Given this list of marker genes RNF4 (NCBI Gene Id 6047), TIMP2, STAMBPL1, TRIM15, PTPRA, FKBP9, RRAS2, NFIA, CYTH1, RAB33A, HIVEP1, KRCC1, ARL4A, SREBF1, WDR31, SERINC4, THRA, ATAD2B, IL10RA, PDZD11, ANKRA2, DOCK2, DLAT, PPP4R2, SAV1, VPS37B, LAMP2, SLC23A2, CSRP1, ASAP1, DEXI, MYCL, LINC00612, TYK2, ETNK1, COLEC12, CALHM2, STIP1, HSD17B6, TMEM243, CPEB1, SERTAD3, SLC7A8, GOT1, RNF14, CDC27, DOC2A, LRRK2, BTRC, CDV3, CLDND1, NEK1, SLC44A2, B4GALT6, STX3, UBXN10, PRAMEF2, CACNG2, HIVEP3, ABCC3, HEXB, PRDM9, VPREB3, SLC37A2, ETHE1, RAB38, SAP30, TBC1D23, GALNT11, DUSP2, MLC1, CSF1, RRS1, FOLR1, STK4, IGF1, SP110, SLC25A17 (NCBI Gene Id 10478), RUNX2, ATP6V1G2, TNFSF10, P2RY14, PTH1R, FAS, SUPV3L1, UBR4, SIK1, EMC2, HMGN3, IFT57, WIPI1, NDUFA5, CACNG3, ABHD5, RNF135, PRKD3, CXCL3, EDEM1, PFKM (NCBI Gene Id 5215), NAP1L5, ASCL1, SLC25A28, SECTM1, VRK2, RAB10, GLA, ZBTB8A, CNP, NPAS1, NCOA5, G3BP2, CCNL1, LPAR4, CDH5, UBE2V1, TMEM39A, B3GNT2, PTPRT, CTSZ, BHLHE41, GYPC, SYNGR1, SLC17A3, QKI, SEPTIN11, KCNS1, EIF2D, ABCD3, MELK, PFKP, NT5C3A, OGFR, PHTF2, WARS1, AVL9, IL5, RGS2, SPRYD7, MRPS28, FAF1, SPRED2, SLC34A2 (NCBI Gene Id 153010), CIP2A, PCDH7 (NCBI Gene Id 90855), TLR3, NAXE, SMPDL3A, GAMT, GTPBP2, BFAR, TBC1D1 (TBC1 domain family member 1), PNPLA7, TOR3A, SGMS1, STK38, MPP1, NBN, INSRR, ACP1, RAB29, PKIG, SLC41A2, IFIH1 (interferon induced with helicase C domain 1), RARA, IK, MSANTD2, RANBP9, NEDD4L, CH25H, PKIB, PLAAT3, SLC25A25, ITGAX, FBXW11, POU3F1, SLC6A4, ACOD1, CHCHD3, LPCAT1, NFKBIB, MLLT3, RASA4, GPBP1L1, GALNS, KCND1, PDLIM7, EGR2, PRPF38A, BATF2, SH3TC1, PSMD8 (NCBI Gene Id 5714), NCK1, IMMT, PARP9, FIP1L1, SGCB, CLEC7A, WLS, ZNF260, here is a description of the gene set: Genes up-regulated in macrophages with MYD88 knockout after M. bovis BCG infection: 24h versus 48h. Nitric oxide (NO) produced by macrophages (MØs) is toxic to both host tissues and invading pathogens and its regulation is therefore essential to suppress host cytotoxicity. MØ arginase 1 (Arg1) inhibits NO production by competing with NO synthases for arginine, the common substrate of NO synthases and arginases. Two signal transduction pathways control Arg1 expression in MØs. First, a MyD88-dependent pathway induces Arg1 in intracellular infections, while a second Stat6-dependent pathway is required for Arg1 expression in alternativelyactivated MØs. We found that mycobacteria-infected MØs produce soluble factors that induce Arg1 in an autocrine-paracrine manner via Stat3. We identify these factors as IL-6, IL-10 and GCSF. We further establish that Arg1 expression is controlled by the MyD88-dependent production of IL-6, IL-10 and G-CSF rather than cell intrinsic MyD88 signaling to Arg1. Our data reveal the MyD88-dependent pathway of Arg1induction following BCG infection requires Stat3 activation and may result in the development of an immunosuppressive niche in granulomas due to the induced Arg1 production in surrounding uninfected MØs Human Gene Set: GSE22935_24H_VS_48H_MBOVIS_BCG_STIM_MYD88_KO_MACROPHAGE_UP from publication Qualls JE, Neale G, Smith AM, Koo MS, DeFreitas AA, Zhang H, Kaplan G, Watowich SS, Murray PJ (PMID 20716764) studied in species Homo sapiens